The following is a description of a gene set: studied in species Mus musculus Mouse Gene Set: GOBP_REGULATION_OF_CONNECTIVE_TISSUE_REPLACEMENT Any process that modulates the frequency, rate or extent of connective tissue replacement., and this is the list of marker genes: Rock1, Klf6, Gata4 (NCBI Gene Id 14463), Rock2, Pparg, Ppp3ca